Given this list of marker genes Cdc20, Adrb2, Grb2, Mief1 (NCBI Gene Id 239555), Tbc1d24, Lrrc4b, Bmp4, Grip2, Stil, Oxt, Mir124a-1, Abca7, Ep300, Ndnf, Nsmce2, Terf2ip, Atg5, Lats1, Fcgr3, Axl, Dynlt1a, Rap1gap, Synj2bp, Faf1, Cd300lf, Tlr4, App, Bok, Shank3, Ppp3ca, Ephb3, Prkd1, Cav1, Stmn2, Angpt1, Cct8, Ccl21a, Add1, Frmd7, Sema7a, Nme1, Add3 (NCBI Gene Id 98171), Rab3gap1, Ankrd53, Siva1, Mylk3, Fnbp1l, Lats2, Amph, Ccl21d, Gnl3, Bag4, Ace2, Scgb3a1, Mex3b, Calcoco2, Trhr, Pros1, Ube2b, Bmp2, Syt1, C2cd5, Prox1, Terf1, Xlr3b, Fyn, Cep120, S100a10, Rac2, Ank1, Clrn1, Disc1, Ajuba, Neurl1a, Camk1d, Il4, Ppp1r10, Map2k7, Flrt2, Ephb1, Nf1, Gbp5, Aurka, Il5, Map3k13, Adnp, Pot1a, Rims1, Pfn2, Sdc4, Rac1, Ntrk2 (NCBI Gene Id 77471), Hfe, Ehd2, Lif, Negr1, Edn3, Lgals3, Wars1, Epha1, Apbb1, Plxnd1, Endog, Cenpj, Slit2, Ddhd1, Hspb1, Ccl8, Opa1, Sfpq (splicing factor proline/glutamine rich (polypyrimidine tract binding protein associated)), Ttbk1, Tsg101, Cldn5, Smc2, Akap9, Tiam1, Epha3, Nf2, Ccl24, Slx1b, Slain1, Sirt2, Actl6a, Il1b, Arhgef15, Cln3, Bik, Tmem30a, Syt4, Nlgn1, Lrrtm4, Ino80b, Cd14, Znrf2, Plxnb3, Itgb1bp1, Lrrtm2, Fermt2, Ncapg2, Katnb1, Igf1r, Myo3b, Actn2, Cnr1, Asic2, Nabp2, Ppp2r5b, Casp7, Dbnl, Pxn, Nedd9, Bnip3, Cfp, Stx18, Pdcd5, Becn1, Cdh5, Epor, Ppp3cb, Phip, Elavl4, Nedd4l, Cdk5rap2, Fbxo38, Cdkl5, Aurkb, Nck2, Tnfsf10, Tgfa, Ahsg, Colec10, Hnrnpa2b1, Gata2, Atg2a, Pdgfb, Map1b, Cdk2, Lrrk2, Mecp2, Adck1, Syt13, Mark4, Map4k4, Mad1l1, Slx4, Caprin2, Plekhm1, Cdc34, Pkib, Efnb3, Ptpn11, Abcc8, Col16a1, Shoc2, Rapgef2, Macroh2a1, Ier3ip1, Prdm9, Nrp1, Cct4, Itga2 (integrin alpha 2), Adgrl4, Scarf1, Bcl11a, Mmp1b, Igf1, Trim65, Appl1, Hmbox1, Caprin1, Tac1, H1f1, Picalm, Bad, Grn, Agrn, Tnks, Baiap2l2, Ccr7, Epn1, Flt3l, Ahi1, Wmp, Frmpd4, Prkce, Cct6a, Meltf, Crp, Mns1, Alox15, Kif3c, Stk24, Actr8, Mapk8, Sod1, Sdc1, Prkcq, Ino80c, Atp7a, Evl, Sumo1, Mapkapk5, Wnt7a, Dock11, Mir124a-3, Wipi1, Magi2, Mllt11 (myeloid/lymphoid or mixed-lineage leukemia; translocated to, 11), Apoa2, Syk, Kif5b, Dcstamp, Tnks2, Atad1, Spag5, Hif1a, Ezh2, Plk2, Tnn, Pmaip1, Gbp2, Sorbs3, Coro1c, Lpar3, Drg1, Nsf, Pip4k2a, Dzip1, Slitrk2, Macf1, Camk2b, Rap1a (RAS-related protein 1a), Dlg1, Itga6, Nckap1l, Ddr1, Dynll1, Fchsd2, Bmp7, Ehd1, Rab3gap2, Snap91, Mtss1, Hsp90aa1, Sh3gl2, Mapk14, Chchd10, Osbp, Spast, Robo1, Mir124a-2, Rala, Tenm3 (teneurin transmembrane protein 3), Calr, Hnrnpd, Tsc2, Anapc2, Ntrk1, Nefl, Rab8b, Il15ra, Rit2, Cbfa2t2, Zfyve27, Wdr1, Dpysl3, Mpp7, Auts2, Fas, Ins1, Gsn, Synpo2l, Ercc1, Syt7, Zmynd10, Plek, Ruvbl2, Nfatc2, Wasf2, Gm14137, Tesk1, Acsl6, Stra8, Hras, Mbl1, Bbc3, Ptk6, Arl2, Lyar, Ntn1, Adgrb2, Grip1, Zfp13, Ube2c, Vps35, Il1rapl1, Ccl21f, St8sia2, Ncapg, Hip1, Lrp5, Arf1, Gdf15, Myc, Zdhhc2, Mre11a, Ssbp1, Pak3, Pcsk5, Vps4b, Serpini1, Pla2g4a, Rph3a, Gdi1, Eif2b2, Spidr, Pgam5, Pdcd6ip, Cbln1, Lcn2, Syt11, Mlst8, Plxnb2, Cdh4, Plk5, Nav3, Parp6, Nusap1, Myo1c, Smcr8, Htr1a, Metrn (meteorin, glial cell differentiation regulator), Kat5, Pcsk9, Tpbg, Dock2, Obsl1, Nox4, Tgfb1, Megf8, Ifng, Erc2 (ELKS/RAB6-interacting/CAST family member 2), Cul3 (cullin 3), Fam162a (family with sequence similarity 162, member A), Cd53, Phldb1, Ska1, Cct2, Pak1, Pip4k2c, Usp8, Pan3, Nup62, Slitrk3 (SLIT and NTRK-like family, member 3), Plcb1, Stk11, Fez1, Abcb7, Coro1b, Nvl, Apoa5, Fis1, Kirrel1, Flot1, Golga2, Vtn, Kdm1a, Sftpa1, Bub1, Tapt1, Pard3, Tom1, Rgma, Limk1, Marchf5, Ino80, Lrp8, Colec11, Alkal2, Cobl, Ncapd3, Met (met proto-oncogene), Tpm1, Ighg1, Cck, Nphs1, Ndrg4, Tulp1 (TUB like protein 1), Dcc, Syt8, Trabd2b, Ube2v2, Atr, Ptges3, Myo18a, Robo3, Vil1, Il15, Sf3a2, Wnk1, Mff, Naf1, Styxl1, Pla2g5, Sftpd, Npm2, Bax, Prkca, Mad2l2, Serpinf1, Itpr1, Baiap2, Cldn19, Wrap73, Map2k2, Il17a, Ptn, Rab27a, Mfn2 (NCBI Gene Id 170731), Csf3 (NCBI Gene Id 12985), Grid2, Syt5, Tenm2, Kit, Rreb1, Irgm2, Prap1, Ndel1, Ncapd2, Bak1, Ankrd1, Itga3, Pick1, Ice1, Prkn, C3, Cpeb1, Tppp (tubulin polymerization promoting protein), Apoa1, Dgkd, Hdac4, Pik3r1, Fpr-rs3, Lrrtm3, Cntnap2, Ghrl, Gpc3, Enc1, Prom2, Syt2, Trpv2, Rps3, Dlg4, Ppt1, Tmem106b, Emilin1, Musk, Lmod2, Fasl, Tbc1d5, Lrp2, Hnrnpk, Colgalt1, Arsb, Gsk3b, Numbl (NCBI Gene Id 18223), Prrt2, Mertk, Psrc1, Pias2, Rgcc, Cfl2, Atp1b2, Tacr1, Ar (androgen receptor), Rnd2, Zmynd8, Adam17 (NCBI Gene Id 236174), Bmp10, Ptprd, Clu, Itgb1, Clec16a, Pan2, Marcks, Fpr-rs4, Pfdn2, Wls, Igtp, Tnf, Synpo2, Sgk1, Fnip2, Zdhhc15, Fer, Ntrk3, Nck1, Dctn1, Ptx3, Cnot2, Creb1, Gpm6a, Lrrc7, Cdc23, Rrn3, Med25, Atf1, Lrrn3, Park7, Pml, Eif4g2, Rab21, Ppm1f, Mapk1, Adgrb1, Cdc42ep5, Atoh7, Mul1, Avil, Ptk7, Hgf, Actn4, Cdc42, Anxa2, Sfrp4, Robo2, Gch1, Tor1a, Insr, Ngfr, Dnm1, Neurod2, Dvl2, Tnik, Lcp1, Tppp3, Jmjd4, Stap1, Ap2b1, Nlgn2, Pld6, Ins2, Asap1, Adgrl3, Cux1, Ddx3x, Kalrn, Moap1, Rapgef3, Caly, Ddx11, Fen1, Sass6, Brcc3dc, Islr2, Ino80d (INO80 complex subunit D), Actr5, Tcp1 (NCBI Gene Id 435546), Pebp1, Wnt11, Cbll1, Terc, Crtc1, Abcb4, Msx2, Cul7, Mtnap1, Arhgef10, Synpo, Sphk1, Thbs2, Lrrn1, Atp10a, Rapgef1, Pip4k2b, Cldn3, Sox9, Arrb2, Nlgn3, Carmil2, Lrtm2, P3h1, Pdgfrb, Bcl2l1, Wnt5a, Wasf1, Cxcl12, Znrf1, Ctnnb1, Syndig1, Vstm5, Plk4, Terf2, Sgo2a, Ppp2ca, Ldlrap1, Piezo1, Ambra1, Pafah1b1, Hspa1a, Myd88, Rab31, Whamm, Arap1, Brk1, Pfn5, Fermt1, Tenm1, Rack1, Doc2b, Ikzf1, Ppm1e, Ccn2, Ptprf (NCBI Gene Id 19268), Ptk2, Nptn, Xrcc4, Iqsec2, Cnot6l, Ager, Scarb2, Npr2, Anln (NCBI Gene Id 97521), Potefam3b, Trim58, Abi2, Cd24a, Lrrtm1, Oxtr, Sirt6 (NCBI Gene Id 72769), Wdr45, Pla2g3, Clasp1, Gpc2, Pnkp, Crabp2, Stk25, Kat2a, Dscam, Efna5, Msx1, Wnt4, Tnxb, Gpihbp1 (GPI-anchored HDL-binding protein 1), Ano6, Slf1, Fam98a, Cdc42ep2, Atp8a1, Abcg1, Gja1, Serpinf2, Fpr2, Isg15, Anxa1, Fkbp1b, Cdc34b, Itpka, Ilk, Lims1, Acvrl1, Pot1b, Poc1b, Wdr35, Eif5a2, Bin1 (bridging integrator 1), Shox2, Nr1h2, Iqgap1, Apela, Ss18l1, Pou4f2, Mib1, Flrt3, Nme2, Baiap2l1, Arhgap35, Abca1, Nek2, Cbl, Dkc1, Eif4g1, Gper1, Pfn1, Efemp2, Actr2, Rtel1, Map3k1, Ereg, Ccl26, Amigo1, Sema4d, Trim32, Gcm1, Cand1, Bmp5, Zdhhc6, Twf2, Fbxo31, Pacsin1, Ckap5, Scin, Stmp1, Sele, Fcgr2b, Mcoln1, Nek7, Dcx, Bbs4, Swap70 (NCBI Gene Id 20947), Capn2, Washc5, Atrx, Phldb2, Ryk, Btc, Tinf2, Tsc1, Doc2a, Akirin1, Carmil1, Smurf1, Tgfbr1, Cldn1, Ppp1r9a, Prl2c2, Agt, Cntf, Epha4, Hsf1, Pqbp1, Camk1, Arpc2, Crbn, Cct5, Dynlt1b, Mcrs1, Ahr, Trim67, Abl1, Flna, Reln, Hoxa13, Fhod1 (formin homology 2 domain containing 1), Adcy10, Bhlhb9, Mob2, Sirpb1a, Efemp1, Ache, Cdc42ep4, Thy1, Ccl11, Sh3glb1, Ranbp1, Saxo1, Rpl4, Qki, Alkal1, Pfn3, Bdnf, Ccdc88a, L1cam, Ccl21e, Ephb2, Myo5b, Ikbkb, Fpr-rs7, Anapc7, Dll1, Zfp804a, Plek2, Nrdc (nardilysin convertase), Hspa1b (heat shock protein 1B), Cxcl5, Lpar1, Fbxw8, Tal1, Amigo2, Syt3, Ubap2l, Adam9, Csf2, Pdcd5-ps, Ncaph, Ankrd66, Rims2, Fig4, Uchl5, Ccdc15, Lman1 (NCBI Gene Id 70361), Il1a, Tub, Pla2g6, Ncaph2, Tirap, Zdhhc5, Cacna1b, Wnt3a, Rock1, Brcc3, Pcp4, Enpp2, Rb1, Psmc6, Cdkn1b, Dag1, Lrp1, Egf, Tpr, Fuz, Snx27, Il1rap, Id1, Lrp4, P2ry2, Pdxp, Snca, Vcp, Adamts1, Erc1, Ptprj, Slitrk1, Bicd1, Ptpn22, Plxnb1, Hopx, Ppp3cc, Wrap53, Itsn1, Def8, Icam1, Dnm3, Drd3, Fcer1g, Slitrk5, Stau2 (NCBI Gene Id 29819), Arhgap32, Alms1, Mad2l1bp, Il2rg, Tfr2, Eef2k (eukaryotic elongation factor-2 kinase, NCBI Gene Id 97404), Fgf8, Slc11a1, Ap2a1, Unc13b, Shtn1, Mstn, Skap1, Btk, Wnt1, Wasl, Tmem67, Rhoq, Fyco1, Trp53, Mbl2, Eps8l3, Kif3a, Cxcl13, Anapc5, Skil, Cct7, Trpv4, Rp1, Atm, Hip1r, Kdr, Igf2, Fzd4, Surf4, Bid, Rock2, Gas6, Piwil2, G3bp2, Mfn1, Rad51ap1, Tiam2, Ppp2r5d (protein phosphatase 2, regulatory subunit B', delta), Tppp2, Cd63, Mmp9, Numb (NCBI Gene Id 18222), Synj1, Abl2, Poldip2, Mdk, Ralb, Sgip1, Lbp, Fpr-rs6, Cask, C2, Nckipsd, Tfpt, B2m, Abr, Dynlt1c, Entr1, Crocc, Cbln2, Septin9, Cux2, Doc2g, Snx9, Bcl2l11, Cx3cl1, Clstn1, Nrxn1, Twf1, Wasf3, Nfe2l2, Sema4a, Atmin, Fn1, Mapt, Lmod1, Trpc5, Myo3a, Gnl3l, Mmp1a, Snx18, F2rl1, Yy1, Trf, Prkci, Nphp1, Smad4, Klf4, Mien1, Clip1, Aplnr, Hdac6, Fxn, Rimbp2 (RIMS binding protein 2), Has3, Lingo2, Sirpa, Mapre1, Atat1, Lrrc24 (NCBI Gene Id 378937), Ptbp1, Cttn, Espn (espin), Msn, Lyn, Tmed9, Slc30a1, Tnfsf14, Cd209b, Stub1, Cdc42ep1, Dazl, Smpd1, Anapc11, Khdc3, Syt9, Palm (NCBI Gene Id 18483), Lingo4, Kctd17, Serpine1, Rufy3, Casp4, Ift88, Numa1, Pde4dip, Lman2, Fbxo5, Adgrl1, Dhx33, Cdkl3, Hspa8, Adgrb3, Eif4g3, Nphp4, Bmf, Abca3, Mief2, Xrcc5, Lnpk, Gda, P2ry12, Sh2b1, Tek (NCBI Gene Id 99999), Cdk1, Epgn, Ptprz1, Ccp110, Git1, Shcbp1l, Epb41l5, Ccl2, Dmd, Ddx56, Ska3, Dync1h1, Ptpn5, Irgm1, Ripor2, Ccl21b, Abca13, Lig4, Arrb1, Dab2, Dixdc1, Atp8a2, Ift20, Usp50, Pum2, Plaur, Bmpr2, Vasp, Dvl1, Cdh17, Nes, Tgfb3, Cracd, Cd36, Scn1b, Ocstamp, Atl3, Apoe, Kidins220, Rad50, Gsk3a, Nrg1, Fbxo4, Pdlim4, Dlg5, Cxcl9, Trim27, Vldlr, Flrt1, Map3k4, Acd, Sema5a, Fut9, Edn1, Cyp2j6, Dhx36, Tlr6, Ooep, Smpd3 (sphingomyelin phosphodiesterase 3, neutral, NCBI Gene Id 80691), Ppp1r35, Cd47 (CD47 antigen (Rh-related antigen, integrin-associated signal transducer)), Gdf2, Atp5if1, Zdhhc1, Dvl3, Neu1, Nox1, Micu1, Cyba, Hap1, Dnm2, Tnfrsf12a, Snx3, Ralbp1, Pparg, Pld2, Clec7a, Htr7, Cyfip1, Fcgr1, Sdcbp (syndecan binding protein), Parn, Mtor, Vegfa, Dstn, Slitrk6, Creb3l2, Golga4, Slain2, Foxc2, Hrk, Potefam3a, Eps8l2, Slf2, Tox, Ddhd2, Cnot1, Hrg, Bcr, Ltk, Snx4, Myh9, Ist1, Mmp3, Tgfb2, Sh3gl1, Cntn1, Ap2m1, Ntf3, Dynlt1f, Tbx5, Aqp1, Ptk2b, Fmn1, Pycard, Gm12250 (NCBI Gene Id 631323), Slc18a3, Slitrk4, Rph3al, Ssh1, Fscn1, Mapre2, Dbn1, Plcg2, Trem2, Alk, Magel2, Crb3, Retreg3, Mtln, Wnt10b, Snx7 (NCBI Gene Id 76561), Afdn, Myod1, Clasp2, Psmc5, Yme1l1, Fnip1, P2rx7, Kat2b, Lrtm1, Dtnbp1, Snx30, Ruvbl1, Ptprc, Htt, Clstn3, Kiss1r, Cdc42ep3, Nin, Arf6, Fmr1, Il6, Katnbl1, Sirt1, Mcu, Pdpn, Ighm, Mapk15, Epha2, Cd28 (NCBI Gene Id 12487), Cct3, Gpr65, Smc5, Ankrd27, Psen1, Clstn2, Ptpn23, Actr3, Zeb2, Dnm1l, Adgrl2, Il4ra, Nbn, Tubb2b, Nckap1, Map6, Rictor, Tfrc, Tyrobp, Mapk9, Adcyap1, Epo, Ighg2b, Braf, Rab3ip, Plxna3, Eps8, Amigo3, Rab11fip3, Meiosin, Arhgef10l, Src, Hamp2, Ret, Irx3 (NCBI Gene Id 16373), Nod2, Gpsm2, Apc, Adgre5, Fes, Gprc5b, Dusp3, Cnot6, Apln, Fzd1, Plxnc1, Ttbk2, Dab2ip, Appl2, Elapor1, Iqsec1, Cep135, Cdc16 (NCBI Gene Id 72610), Smad3, Pink1, Lrsam1, Hamp, Dsg3, Rasip1, Trak1, Eif5a, Ulk1, Grem1, Rhoc, Rhoa, Clip3, Cfl1, Cav3, Oga, Setx, Limch1, Dmrt1, Eps8l1, Mapk3, Plppr5, Serpine2, Spire1, Hyal1, Cpb2, Fgfr1, Gba1, Dcn, Ngf, Map2k1, Rap1b, Sh3pxd2b, Hspa5, Il2rb, G3bp1, Ankfy1 (NCBI Gene Id 11736), Mark2, Ddr2, Lrp6, Srf, Cenpe, Rgs2 (regulator of G-protein signaling 2), Wnt3, Ccl19, Cd151, Fcnb, Plce1, Drd2, Arhgef5, Vps28, Myoc, Grin1, Chodl, Togaram1, Fchsd1, Akap5, Srpx2, Cflar, Smc4, Rad21, Mavs, Cep295, S100a9, Nfrkb, here is a description of the gene set: Mouse Gene Set: GOBP_POSITIVE_REGULATION_OF_CELLULAR_COMPONENT_ORGANIZATION Any process that activates or increases the frequency, rate or extent of a process involved in the formation, arrangement of constituent parts, or disassembly of cell structures, including the plasma membrane and any external encapsulating structures such as the cell wall and cell envelope. species: Mus musculus